Given this list of marker genes MARS1, NDUFAF5, GNPTAB, MUC1, KIFBP, PROKR2, DYNC2H1, PIK3CD, PXK, KAT6A, LFNG, ERCC8, AIP, TBX3, PGAM2 (phosphoglycerate mutase 2), TBX15, ATP5F1E, MAD2L2, SDHA, LMNB1, CASZ1, EP300, FANCF, HGD, HIC1 (HIC ZBTB transcriptional repressor 1), ARID1B, AMER1, HDAC4, RAP1B, PRKACB, FUZ, GLI3, TBX18, PEX26, KCTD1, ATPAF2, XRCC4, TMEM260, SNRPN, MTX2, MT-ATP6, FOXI1, TP53, PAX6, B3GALT6, ELN, STAT3, NOTCH3, NKX2-1, KNSTRN, MSH3, CFI, AFF4, MPV17, STS, EYA1 (NCBI Gene Id 2138), GNB2, SI, INSL3, YRDC, POLR3A (NCBI Gene Id 11128), CACNA1D, BRCA2, LRP4, PROK2, TNFSF4, WNT5A, RRAS2, NEK8, ALG1, DNASE2, APPL1, CHRM3, CLDN16, PHYH, SLC41A1, STXBP2, DLL3, RSPO2, SEC63, PKDCC, B2M, MVK, NRAS, REST, PI4KA, TP53RK, NDUFV2, PIGY, ALG5, TNIP1, KCNQ1, NELFA, BUB3, IFT56, CLEC7A, CHUK (NCBI Gene Id 1147), STAT1, C1GALT1C1, CDKN2C, DISP1, MT-ND4, ATP7A, IFT122, F5, CYB561, GON7, GPC4 (glypican 4), AKT1, RIPK4, COG6, GRIP1, BLK, ZBTB18, MGME1, NCF1, PHKA2, SEC23B, HESX1, TCTN3 (tectonic family member 3), C1S, RPL35, CEACAM6, MEFV, FGF23, CCND2, REN (NCBI Gene Id 5972), XYLT1, AFF3, BMPER, ANKS6, TRIP11, IDH1, UBE2L3, HBB, BBS4, SOX9, CDC73, IFT74, FCGR3B, B3GLCT, RPL11, TTR, CHST14, WASHC5, FEZF1, MMUT, GP1BA, IL17F, NIPAL4, BRF1, RPS24, MDH2, FAM20C, TIMMDC1, C4B, RPS27, FIBP, FANCB, DDB1, WFS1, SLC17A5, WDR4, NF1 (NCBI Gene Id 646021), CDKN2B, ITGAM, RNF139, ARHGAP24, RRAS, TBK1, BMP4, EBF3, CLIP2, MASP1, UBE2A, NDUFS1, SKI, CD151, ALG9, VDR, SLC9A3, ITGB4, FOXE1, MLH3, SCNN1A, FGFR3, GRIN1, HLA-DPB1, STIM1, EDNRB, IFIH1, HNF4A, CEP152, ITGA2, GNAO1, NABP1, ABCG8, ZNF699 (NCBI Gene Id 374879), RPS15A, SEMA3A, GNAS, PAX7, CTBP1, PHKB, GATM, HS2ST1 (heparan sulfate 2-O-sulfotransferase 1), HYLS1, ATP5F1D, EPG5, CFB, YY1AP1, NHERF1, ALX4, CENPE, THOC6, COL4A3, NPHP1, CEP83, POGZ, BRAF, PMM2, C2CD3, MIF, KDM6A, ACVR1, TCTN2, HLA-DRB1, OFD1, STX3, CCDC22, DDX6 (DEAD-box helicase 6), COL3A1, HYMAI, SMARCA4, PTH (NCBI Gene Id 5741), AKT3, HMBS, WT1, DNASE1, CEP57, PEX12, CEACAM3, RBM10, NXN, DNMT3A, IFNGR1, LYZ, RAB3GAP1, RPS28, POLD1, PSMC1, CTU2 (NCBI Gene Id 348180), HNRNPK, LAMB3, MID1, CTLA4, PKD1, PML, NOS1AP, RBCK1, ALG8, SPART, GALNT3, FGF20, GATA1, RPS7, FGF13, SAA1, GATA4, COLEC10, FANCL, MKKS, SLC2A9, ITGA8, YAP1 (Yes1 associated transcriptional regulator), RIT1, RORA, INPP5E, CNNM2 (cyclin and CBS domain divalent metal cation transport mediator 2), WDR73, SLC12A1, LMOD1 (NCBI Gene Id 25802), USF3, CHEK2, TAOK1, STRA6, NUP93, RPGRIP1, SLC30A9, MCM7, TAPBP, MAGED2, RPL5, PPFIBP1, RPS29, LIMK1, LCAT, SEMA4A, PIK3CA, ZNFX1, PHC1, PRF1, MT-TS2, PRKCSH, NEU1, PCSK9, TMCO1, RPS20 (NCBI Gene Id 6224), ABCG5, CEP63, CLCN3, SOX17, ADAT3, TRIM37, COL14A1, MYT1L, AVPR2, MYO1E, PEX14, GPKOW, HNF1B, EVC (EvC ciliary complex subunit 1), INS, PIGA, PTPRJ (NCBI Gene Id 5795), FOCAD, PIGT, NOTCH2, PGAP3, IKZF1, F9, HELLPAR, CPT1A, RPGRIP1L, VAC14, DSTYK, SPRY4, ALDH18A1, NDUFA11, IL12A-AS1, DLC1, POU6F2, ACSL4, PEX11B, PEX6, SLC4A2, PRTN3, MYOD1, LMNB2, DICER1, CYP4F22, DHCR24, SPINK5, CFAP418, SMARCD1, DSE, MMACHC, PHEX, BCOR, TRIP13, SEMA3E, CDH11, LEMD3, AMMECR1, IFT172, STAMBP, TALDO1, LHX1, XPNPEP3, MT-ND1, GATA3, SH2B1, COPA, BMPR1A, AGGF1, SCAF4, PPP2R3C, NDUFV1, NLRP3, SMO, GRB10, POMT2, MRPS34, ADA, DNA2, STOX1, HNRNPH1, NPM1, RYR1, IL6, METTL5, PLD1 (NCBI Gene Id 5337), OTUD5, EXTL3, ACP5, GP1BB, CTH (NCBI Gene Id 63046), DZIP1L, HSPA9, KRT17, PRKAG2, AIRE, NUP160, MYMX, MST1, DHDDS, SETBP1, FAT4, ADA2 (adenosine deaminase 2), AGPAT2, GEMIN4, IL17RA, PEX5, SLC37A4, FAM149B1, MRAS, KIAA0753 (NCBI Gene Id 9851), DPYSL5, MT-TL1, EBP, OSGEP, BICC1, FGA, SDHB, FAM20A, GCK, WARS1, ZBTB16, NCAPG2, MAPKBP1, MDM2, TMEM127, NARS2, NIPBL (NIPBL cohesin loading factor), CD109, TGM1, PKD2, BUB1B, TMEM237, COL6A1, ATP6V1B1, MAPK1, PEX2, PIK3R2 (NCBI Gene Id 5296), SPP1, ITPR1, NEUROD2, METTL27, RAI1, SON, GRHPR, NDUFS8, MOCOS, CCN2 (NCBI Gene Id 1490), DHCR7, CCBE1, H4C5, XDH, MT-TK, PIEZO2, HNRNPU, BRD4, CHKA, SRP54, CIT, KCNJ2, NEXMIF, SLC34A3, RARB, KAT6B, FBXW11, LRP5 (LDL receptor related protein 5), DCHS1, PBX1, ARID1A, KCNJ5, TYR, RNU7-1, SNAI2, NDUFAF2, DLL4 (delta like canonical Notch ligand 4), IL7R, PLEC, ATP7B, TTC8, TBX22, TBX4, STAT2, KANK2, CAMKMT, ATP6V1B2, KCNJ10, ARX, MPDU1 (NCBI Gene Id 9526), AHI1, FCGR2C, SALL1, AVIL, PDCD1, AQP2, HSD17B4, MSH2, FOXF1, NDUFAF4, FANCD2, SLC26A4, GRM7, DNAJC30, MRPS22, TLR7, PLCD1, CYP24A1, ARMC5, CD2AP (CD2 associated protein), IFT80, FXYD2, PBRM1, ANKFY1, FGFR2 (fibroblast growth factor receptor 2), BAP1, SIX5, MAP3K1, STX11, FOXRED1, DYNC2I2, LRP2, LMAN1, IFT43, KAT5, MBTPS2, FLII, SNAP29, CFHR1, COL4A5, G6PC1, TMEM126B, WDR62, PDCD6IP, PTH1R, GCM2, LMBRD1, BBS9 (NCBI Gene Id 27241), MAGI2, ARVCF, MIA3, MED25, DVL3, ABCC6, SPTBN1, CUBN, OGG1, KIAA0319L, CASR, SLC34A2, F8, NUP37, PAX4, KCNN4, DLG5 (NCBI Gene Id 9231), CRB2, PDPN, NSD2, MESP2, BCS1L, DLL1, JAZF1, STX1A, PRPS1, TACR3 (tachykinin receptor 3), STAT4, BANK1, ROBO1, RAD51C, DIS3L2, SUFU, RMND1, COQ6, MOCS2, CPLANE1, PGAP2, MLX, ITGA3, OBSCN, DVL1, TBC1D20, BNC2, ENPP1, EHMT1, GBA1 (glucosylceramidase beta 1), ACE, MOCS1, AP1S3, LAMC2, SKIC3, IFT140, USP9X, MYD88, SCN1B, ABCC8, SPRY2, FAN1, DCLRE1C, SBDS, PRDM16, VHL, APOL1 (apolipoprotein L1), NDUFS2 (NADH:ubiquinone oxidoreductase core subunit S2), UBE4B, SCARB2, IQSEC2, POU3F4, FN1, SHPK, LAMA3, HDAC8, CDC42, FLNA, BSCL2, CHRNA3, RPS26, SF3B4, VPS37D, WDR19, GTF2IRD2, PRKAR1A, SRCAP, COQ8B, SOX10, YWHAE (tyrosine 3-monooxygenase/tryptophan 5-monooxygenase activation protein epsilon), ZNF423, PDGFRL, ACBD6, CCR6, ALDH4A1 (aldehyde dehydrogenase 4 family member A1), CTNS (NCBI Gene Id 1497), RPL35A, MYLK, CTNNB1, KCNH1, ATN1, MAP2K1, CDKN2A, CEP290, LZTR1, PRKCD, HFE, PDE6D, AXIN2, BLM, CDK4, JAM3, IFT27, TP63, UFD1, SLC6A17, FAH, COQ7, ALDOB, TRMT5, IL36RN, BICRA, PTPN12, PIGQ, ZFPM2, FREM2, GREB1L, GPR35, COG7, PRDX1, MCPH1, CASP10, KARS1, NDUFB11, ETFDH, WBP4, PRKACA, HPS1, GNB1, HEATR3, IL17RD, PREPL, NR5A1, RAG2, CA2, BUB1, NDUFB3, MT-TF, SHH, TASP1, TRAF3IP2, SPINT2, BRCA1, LRIG2, MED11, MT-ND3, SMS (spermine synthase), CEP164, TOR1A (torsin family 1 member A), ZIC2, SALL4, LZTFL1, SLC12A3, SPEN, ANOS1, CALR, SMC3, IL23R, AURKA, NDUFA1, TRRAP, GAPVD1, ARHGDIA, GDF3, H19, DHX37, NODAL, NOP10, NDNF, TCN2, CLDN10, PIK3C2A, PEX1, CHD4, SF3B2, SRC, BBS7, SCAPER, KCNE5, TOPORS, FCGR2B, SKIC2, TXNDC15, IPO8, EFEMP2, RASA1, IL12A, CEP19, SLC26A9, ADAMTSL1, RNU4ATAC, ATP5MK, PLG, KCNAB2, TBXT, FCGR2A, CILK1, USP8 (NCBI Gene Id 9101), SLC22A12, NFIA (NCBI Gene Id 4774), GNA11, HLA-B, RREB1, WWOX, MT-TN, SLC26A1, CPOX, DBR1, BBIP1, PRCC, COL4A1, MECP2, SLC1A2, RAB23, INTS1, PCK1, SPRED1, EXT2, G6PC3, EIF2AK3, HOGA1, BTNL2, GABRD, STX5, RAP1GDS1, CDKL5, UNC13D, CEP135, NDUFAF3, GLI2, GLI1, MCTP2, STRADA, NAA10 (NCBI Gene Id 8260), ZMYM2, FKRP, TBC1D8B, CENPF, GATA6, PDHA1, MT-ND6, SMARCB1, IARS1, KMT2D, MLH1, TGIF1, TSR2, RPL26, SRRM2, CLDN2, RALGAPA1, LTBP4, SSR4, HOXD13, MAB21L1, FASLG, ACTN4, DNAJC21, TELO2, FLI1, SLC4A4, ALDOA, VIPAS39, DHODH, HLA-DPA1, PRODH, RBM8A, HMGA2, PRKCZ, ETS1, IL17RC, WNT3, CCND1, GLA, RASA2, ITPR3, RTL1, NUP107, PTPN11, DPF2, ISL1, SOX18, SOS1, COL18A1, CDK6, SLC2A2, DOCK11, WNT9B, SLX4, FOXP3, DNAJB11, EPAS1, COA8, TRPS1, HES7 (NCBI Gene Id 84667), CPT2, LARGE1, NPHP3, CACNA1S, NR0B1, ADNP, MED12, CDKN1B (cyclin dependent kinase inhibitor 1B), PYGL, POR, LPIN2, MYH11, CYBC1, FKBP6, C4A, SERPINF2, SHOC2, BBS12, TRPC6, TKT, SPECC1L, KCNA1, BRIP1, TAPT1, H4C9, KCNJ11 (potassium inwardly rectifying channel subfamily J member 11), IFNG, XRCC2, POLRMT, TNFAIP3, TCTN1, PMS2, APOA1, PHF21A, NDUFS7, LAMA5, SIX2, PALB2, ESCO2, PEX10, GTF2IRD1, BBS5, SLC29A3, NUP205 (NCBI Gene Id 23165), CDKN1A, NSUN2, YY1, PLA2G2A, CFHR5, TRAF3IP1, ZMPSTE24, KYNU, ALOXE3, TXNL4A, CCDC28B, CEP41, KLLN, SDHAF2, LIG4, ERCC6, SARS1, DEPDC5, PCK2, C1QBP, SLC3A1, CR2, MAPRE2, TSC1, ANLN, CWC27, MAFB, RMRP, CDK5RAP2, DGKE, INSR, LAMB2 (laminin subunit beta 2, NCBI Gene Id 3913), PRMT7, MCFD2, AGXT, DAAM2, EPCAM, UQCC2, MYH9, CDC42BPB, ARPC4, TRIM32, UBA2, TBCK, SLC7A9, CPLX1, SLC1A1, SLC25A11, MT-TH, SIX1, DYRK1A, ARL6IP6 (ADP ribosylation factor like GTPase 6 interacting protein 6), NDUFS6, SMARCAL1, KCNJ1, NDUFB10, CFTR, LETM1, PLAGL1, RPL27, PUS3, UNC45A, INTU, CCDC141, SLC25A22, MT-CYB, IGF2, MSH6, VPS35L, MAPKAPK5, EHHADH, SLC5A2, ARID2, MYO5B, TMEM138, RARA, VAMP7, PNPLA6, FGF17, ZNF148, TMEM67, GAS1, APC, ZEB2, ZIC3, GSTM3, RBBP8, MT-CO2, FIP1L1, ITGB3 (integrin subunit beta 3), DACT1, TOGARAM1, KRAS, RFWD3, MT-TV, CEL, MRPL3, PRDM10 (NCBI Gene Id 56980), CEP120, AGT, CC2D2A, MUTYH, ZMIZ1, TLR2, TULP3, FAS, NUMA1, TRPV6, RPS19, HRAS (NCBI Gene Id 338029), WDR35, INVS, PMS1, LPIN1, SOCS1, EIF4H, GSN, MMP23B, SLC11A1, SNRPB, SMC1A, ACTG2, PGM1, UBAC2, F10, HMOX1, FGF8, GLIS2, TBL1XR1, ROR2, DCDC2, LTBP1, SLC32A1, H4C3, SIX3, FANCG, NUBPL, ERCC4, SCNN1B, HNF1A, MPI, MLXIPL, TMEM270, ASXL1, SCNN1G, KLRC4, CLCNKA, PEX13, XYLT2, ARSK, ZMYM3, LDLR, TGFB1, KITLG, UBR1, MT-ATP8, ZAP70, NTRK1, BCKDK, PORCN, TMEM70, MT-TW, SPOP, COQ2, FKTN, CBL, ASL, CLDN19, C3, POLE, MEN1, KIRREL1, ZNF592, IVD, XIAP, ANTXR1, SASS6, HIRA, SLC35A2, MITF, TRNT1, WLS, TRAPPC14, DHX16, SLC36A2, TAF6, SLC25A20, CISD2, KMT2A, EMP2, FANCA, NUP133, COPB2, SMARCE1, FGFR1, PDGFRB, TRIM8, CAV1, GDF6, PNKP, IRF2BP2, NEK1, DNASE1L3, ROBO2, SRY, CDKN1C, BBS2, TNXB (NCBI Gene Id 7148), SCN2A (NCBI Gene Id 94312), MT-CO1, SOX4, ERBB3, BBS1, BPTF, RAD51, ZFX, RRM2B, ADCY10, GPC3, PC, PEX7, NOD2, STXBP1, FGF10, CAMK2A, PYGM, KANSL1, LACC1, F2, TFAP2A, WNT4, IRF5, LIPN, B4GAT1 (NCBI Gene Id 11041), AKR1D1, ETFA, SUCLG1, SMARCC2, SERPINA1 (NCBI Gene Id 5265), RAD54B, PPP3CA, KMT2C, SPRED2, SCARF2, NECTIN1, RAD21 (RAD21 cohesin complex component), UBE2T (ubiquitin conjugating enzyme E2 T), AXIN1 (NCBI Gene Id 8312), PYCR2, RET, HPSE2, PIGP, RAB18, OCRL, FANCM, PAFAH1B1, PAX1 (NCBI Gene Id 5075), PTCH1, ALPL, FOXP1, MCC, HSPG2, ARL3, STAG1, KIF14, PQBP1, SDHAF1, INF2, PFKM, TBC1D7, AP2S1, TMEM231, COLEC11, CFH, SLC7A7, NDUFAF1, CFHR3, WDR11, DDX59 (DEAD-box helicase 59), NPHP4, PTPN22, PGM3, VANGL1 (NCBI Gene Id 81839), MFSD2A (MFSD2 lysolipid transporter A, lysophospholipid), SEC24C, NFS1, GLMN, TBX1, MT-TQ (NCBI Gene Id 4572, mitochondrially encoded tRNA-Gln (CAA/G)), COL4A6, ATP6V1E1, GRIA3, POLR1A, ATP1A1, IQCB1, TREX1, FBXL4, LUZP1, ERI1, CCR1, SCLT1, GP9, PKHD1, LDLRAP1, TMEM107, WAC, C1QA, B9D1, HSD11B2, MAP2K2, NDUFAF8, PDX1, PLCE1, BAZ1B, ATP6V0A4, GCDH, FLNB, FLCN, SC5D, MNX1, RPL18, IGHG1, PEX16, RPS10, NSDHL, WDPCP, SEC61A1, OPLAH, NRIP1, SLC4A1, TTI1, APOB, FUT8, ERAP1, CCNQ, BAX, CASK, COMT, FLRT3, ADAMTS3, ALKBH8, TPRKB, LMX1B, RFX7, SGPL1, TMEM165, PDSS2, PLVAP, ETFB, MYCN, PEX19, CAD, ITGA6, HPRT1, FBN1, KIF1B, APC2, TSC2, CLPB, EXT1, DUSP6, PTEN, TLR4, EDNRA, PUF60, NDUFB9, STK11, CD46, ASXL2, UMPS, TMEM218, MINPP1, DMXL2, RIPPLY2, KDM1A, PIGV, PIGO, NSD1, SIK1, APRT (NCBI Gene Id 353), LAGE3, DLK1, PPOX, ANKLE2, DMP1, JAK2, CHN1, PHKG2, EVC2, RFC2, RTTN, SREBF1, TMEM216, ZFP57, ZNF687, PIGG, LIG1, NBN, NPHS2, AMN (NCBI Gene Id 81693), CLCA4, LARS2 (NCBI Gene Id 23395), OCLN, CAPN15, ABCA12, TBL2, TTC21B, AGTR1 (angiotensin II receptor type 1), GTF2I, WAS, TBC1D24, CRELD1, CHD7, PPP1R15B, CRIPTO, ITGA2B, DLST, JMJD1C, ANKRD17, KIF7 (kinesin family member 7), MYL9, PGK1, OXGR1, CREBBP, TWIST2, KIAA0586 (KIAA0586), KEAP1, ALOX12B, SLC34A1, ARPC5, NADSYN1, PLXNA1, STAT5B, DCTN4 (dynactin subunit 4), ELP1, WNT7B, NDUFS4 (NCBI Gene Id 4724), RPS17, SULT2B1, SEMA4D, IL12B, RAG1, MYMK, PTPRO, SDHD, NUP85, ATRX, UMOD, DCC, RAB3GAP2, MKS1, SLC5A1, ASPM, ADGRG2, VPS45, TRAPPC10, ACTG1, SMOC1, NADK2, GANAB, WIPF1, MEG3, SDCCAG8, TAF13, KCNQ1OT1, RERE, IRAK1, GFRA1, ZPR1, JAK1, NDUFA6, CD96, IL2RG, HS6ST1, SOX11, MT-ND5, RPL15, MT-TT (NCBI Gene Id 4576), SHANK3 (NCBI Gene Id 85358), RRAGD (Ras related GTP binding D), B9D2, PNPLA2, ARNT2, TAF4, IL10, MAP3K7, ATP5F1A, FOXC2, PIGL, WBP11, TGFBR2, AAGAB, CDON, PIGW, CORIN, SARS2, GBE1, FANCE, FIG4, MEOX1, MMP1, TFE3, BBS10, COG1, FH (NCBI Gene Id 83748), PRIM1, CLCN5, TCF4, TRIM28, DYNC2I1, ALMS1, RPL8, NCAPD3, LONP1, NPHS1, RAF1, FANCC, STIL, HABP2, COL7A1, UFC1, PPM1B, VPS33A, MYRF, SAT1, SURF1, MCM5, LDHA, NDUFAF6, DYNC2LI1, GLIS3, RPL9, PAX2, NEUROD1, BUD23, FREM1, FANCI, PEX3, PIGN, SERPINH1, CSPP1, KNL1, COX14, GCLC, PSMD12, MT-ND2, SOS2, HOXA13 (homeobox A13), WRN, CLCN7, ASPRV1, VPS33B, MTRR, PPP2R1A, FRAS1, CDC45, PIDD1 (NCBI Gene Id 55367), DKC1, ADAMTS13, PHGDH, MME, POMT1, CRTAP, MT-CO3, MAX, SLC6A14, DPH2, KLF11, FBLN5, ATM, HAAO, MET, EN1, LMNA, DPH1, ACTB, DEAF1, CLCNKB, SDR9C7, FOXH1, PACS1, PAK2, RECQL4, BSND, PAH, NDUFS3, CD81, KL, APOE, JAG1 (NCBI Gene Id 3715), COL4A4, FLT1, ARL6, SDHC, MYOCD, THBD, RPL31, CEP55, P4HA2, USP18, here is a description of the gene set: species: Homo sapiens Abnormality of the upper urinary tract Human Gene Set: HP_ABNORMALITY_OF_THE_UPPER_URINARY_TRACT An abnormality of the upper urinary tract.